The following is a description of a gene set: species: Homo sapiens Human Gene Set: GOBP_REGULATION_OF_MYELINATION Any process that modulates the frequency, rate or extent of the formation of a myelin sheath around nerve axons., and this is the list of marker genes: SOX10, MTMR2, TMEM98, TNF, PTPRZ1, LPIN1, KIF14, AKT1, RARB, IGF1, PTN, TENM4, TYMP, ZPR1, ITGAX, EIF2AK3, CDK18, PARD3, LGI4, CTNNB1, JAM2, RARG, NSUN5, TG, RNF10, TNFRSF1B, DLG1, HES5, NRDC, FIG4 (FIG4 phosphoinositide 5-phosphatase), SIRT2, NCMAP, EGR2, MAG, QKI, DICER1, TNFRSF21, MYRF, DAG1, CTSC, NKX6-2, TPPP, WASF3, S100B (S100 calcium binding protein B), MTOR, CST7, RARA, ZNF488